Given this list of marker genes Zfp217, Pde1c, Ppm1h, Cbfa2t3, Mapk1, Wiz, Prkd1, here is a description of the gene set: from publication Chen Y, Wang X (PMID 31504780) studied in species Mus musculus Genes predicted to be targets of miRBase v22 microRNA mmu_miR_7004_5p in miRDB v6.0 with MirTarget v4 prediction scores > 80 (high confidence targets). Mouse Gene Set: MIR_7004_5P